Given this list of marker genes SLC24A4, SEMA4C, H1-0, JDP2, SLCO2A1, CLEC3A, KLHL2, SMTNL2, CHGA, MYLK2, ST6GALNAC5, TSLP, ITGB8, VEGFD, ANKRD28, ZNF384, WDR81, EIF4EBP3, ZNF436, ANP32A, PGF, NR1H3, SMARCA1, SLC9A5, ALDOC, ZNF768, SIK1, TLK2, ZCCHC3, SLC15A2, RNF41, TREX2, NAA50, NCALD, VPS37A, CITED2, KCNH2, FAM193B, LMNA, ENPP1, STON1-GTF2A1L, XPR1, FHOD1, SMAD6, REG3G, NDUFS2, TRIM46, FGF4, STAT5B, ZBTB5, HMGN2, KIRREL2, BAHD1, ZNF710, SOX14, NOL4, KLF13, ENSG00000204117, DDIT4L, DNAJB4, LOX, NFKBIA, ABHD17B, ACVR1, PATL1, ATP8B3, NOSTRIN, BCAR3, LPCAT3, RBFOX2, SOBP, EP300, NTNG2, MPP2, ATP6V1A, BBOX1, DUSP10, STMN4, IL2RA, PRSS36, NFIA, HOXA6, KLHDC8B, KATNAL2 (katanin catalytic subunit A1 like 2), PIPOX, ZNF687, JAZF1, PTMA, SPINK5, GLS, STAT3, WDPCP, RAPGEF5, CLCN2, RARB, MGAT4A, GABBR2, CSDE1, VCPKMT, GSX1, COPG2, NFATC3, CACNB1, DLX3, DUSP14, KRT4, IGSF8, EFNB1, SFRP2, YBX1, WNT16, ZNF436-AS1, POSTN (NCBI Gene Id 10631), TAOK2, LGR6, MTSS1, MYCL, FAM193A, ARL4D, NLGN3, RAB30, DCT, NUDCD1, LGALS9, TMEM192, CACNA1C, CDH10, SETD7, STARD3, PROP1, CFI, PTH1R, LAMB2, MCAM, FBLIM1, HIPK1, EPHB2, LOXL1, NAV2, EBF2, MGST1 (microsomal glutathione S-transferase 1), TXLNGY, DNAH11, ASPN, AFF4, BCL9, RETNLB, GCM1, TEK, ARCN1, SESN3, MSTN, TANK (NCBI Gene Id 10010), RRAS, ZNF148, CYP1A2, ADAMTSL1, VWA1, SYTL2, EXTL3, COL11A2, EIF4G2, SYT9, LRRC59, MAP4K5, EIF2A, GJA3, KMT2E, IRS4, B3GALT2, RALGPS2, SP7, CD82, JPH4, CACNA2D1, GPD1, YARS1, CNOT7, SLC26A7, MIR22HG, MOV10, SLC2A12, TMEM126B, SOX4, SERP1, C9orf85, MBNL1, GPR158, PAX3, MDGA2, LRRTM1, CBFA2T2, SALL1, KLHDC7A (NCBI Gene Id 127707), RHOQ, NCKAP5, GPR173, APLN, SLITRK6, ATF4, RASGRP2, MBNL2, TP53TG1, SLC2A4, HOXB5, PDZRN4, CNTNAP4, RUSC1-AS1, TLX3, CCDC140, SPRY1, SOAT1, NOX3, MORN4, STK36, FBXL20, SOX2, FGF11, TMEM35A, TGIF2, NRXN2, CROT (carnitine O-octanoyltransferase), AAK1 (NCBI Gene Id 652453), POLR2H, CSRNP1, OVOL2 (ovo like zinc finger 2), MRTFA, RNF25, RHOJ, CLDN10, UBE2D3, SCUBE2, SCLT1, SAMD12, KRTCAP2, JPH1, RPE65, TRERF1, SULT2A1, PPP2CA, STON2, MID1, B2M, RUNX1, LINC00474, ORMDL3, HBP1, PPM1D, TYR, SYT8, REM2, SV2A, CHMP2B, BMP6, SPMIP5, SLC35G2, ZIC5, ZSWIM8, ALK, NACA, CYP26B1, H1-10, GDPD2, CIPC, GARIN1B, TMEM229B, TUG1, H3-3B, RBP2, PTGDS, JUP, HIP1, PAG1, PCDHGC3, EXOC6 (NCBI Gene Id 54536), C4orf33, here is a description of the gene set: Human Gene Set: NF1_Q6_01 Genes having at least one occurrence of the motif NTGGNNNNNNGCCAANN in the regions spanning 4 kb centered on their transcription starting sites. This matches the NF1 transcription factor binding site V$NF1_Q6_01 (v7.4 TRANSFAC). studied in species Homo sapiens